Given this list of marker genes RPS27A (NCBI Gene Id 6233), HGF, PTPN2, LRIG1, PTPRJ, USP8, STAM2, SH3KBP1, UBB, GRB2, MET, SH3GL2, EPS15, UBC, HGS, SH3GL1, UBA52, SH3GL3, PTPN1, STAM, CBL, here is a description of the gene set: studied in species Homo sapiens Signaling by MET receptor is negatively regulated mainly by MET receptor dephosphorylation or MET receptor degradation. Protein tyrosine phosphatase PTPRJ dephosphorylates MET tyrosine residue Y1349, thus removing the docking site for the GAB1 adapter. Protein tyrosine phosphatases PTPN1 and PTPN2 dephosphorylate MET tyrosines Y1234 and Y1235 in the kinase activation loop, thus attenuating catalytic activity of MET. The E3 ubiquitin ligase CBL promotes ubiquitination of the activated MET receptor and subsequent MET degradation. CBL contains a RING finger domain that engages E2 protein ubiquitin ligases to mediate ubiquitination of MET, which may occur at the cell membrane or in the early endocytic compartment. Ubiquitinated MET is degraded in a late endosomal or lysosomal compartment in a proteasome-dependent manner. The involvement of proteasome in MET degradation seems to be indirect, through an effect on MET endocytic trafficking. LRIG1 promotes lysosome-dependent degradation of MET in the absence of HGF-mediated activation.<br>MET-mediated activation of RAS signaling is inhibited by MET receptor binding to MUC20 or RANBP10. part of: Signaling by MET Reactome Pathway: Negative regulation of MET activity